Given this list of marker genes TET2, RNU7-1, MEFV, RNASEH2C, ADAR, SAMHD1, LSM11, TREX1, WIPF1, THPO (NCBI Gene Id 84434), RNASEH2A, PIK3R1, JAK2, ASXL1, ABL1, MPL, SRSF2, PTPN6, BCR, KIT, RNASEH2B, IFIH1, WAS, here is a description of the gene set: species: Homo sapiens Chronic leukemia Human Gene Set: HP_CHRONIC_LEUKEMIA A slowly progressing leukemia characterized by a clonal (malignant) proliferation of maturing and mature myeloid cells or mature lymphocytes. When the clonal cellular population is composed of myeloid cells, the process is called chronic myelogenous leukemia. When the clonal cellular population is composed of lymphocytes, it is classified as chronic lymphocytic leukemia, hairy cell leukemia, or T-cell large granular lymphocyte leukemia.